Given this list of marker genes Cyp19a1, Cyp39a1, Pomc, Cyp11b2, Nr1h4, Fdx2, Fdx1, Cyp7a1, Cyp46a1, Cyp4v3 (NCBI Gene Id 102294), Cyp1b1, Cyp51, Arnt2, Fdxr, Ncoa1, Cyp8b1, here is a description of the gene set: studied in species Mus musculus electronically inferred by orthology from the curated human pathway This event has been computationally inferred from an event that has been demonstrated in another species.<p>The inference is based on the homology mapping from PANTHER. Briefly, reactions for which all involved PhysicalEntities (in input, output and catalyst) have a mapped orthologue/paralogue (for complexes at least 75% of components must have a mapping) are inferred to the other species. part of: Cytochrome P450 - arranged by substrate type Reactome Pathway: Endogenous sterols